The following is a description of a gene set: Human Gene Set: PID_INTEGRIN2_PATHWAY Beta2 integrin cell surface interactions studied in species Homo sapiens from publication Schaefer CF, Anthony K, Krupa S, Buchoff J, Day M, Hannay T, Buetow KH (PMID 18832364), and this is the list of marker genes: ICAM4, JAM3, ICAM1, CCN1, F11R, FGG, ITGB2, SPON2, THY1, GP1BA, F10, FGA, PLAU, ITGAL, ITGAX, ICAM3, PLAUR, KNG1, FCGR2A, ITGAM, FGB, ICAM2, PROC, ITGAD, C3, CD40LG, PLAT, VCAM1, TGFBI